Given this list of marker genes Tbx1, Nrp1, Lrp2, Notch1, Ctnnb1, Vegfa, Tgfbr1, Hand2 (NCBI Gene Id 15111), Sec24b, Arid2, here is a description of the gene set: Mouse Gene Set: GOBP_CORONARY_ARTERY_MORPHOGENESIS The process in which the anatomical structures of coronary arteries are generated and organized. Coronary arteries are blood vessels that transport blood to the heart muscle. species: Mus musculus